Given this list of marker genes Cdk2, Rara, Cdk4, Cebpa, Rxra, Cdkn1a, here is a description of the gene set: species: Mus musculus Mouse Gene Set: REACTOME_TRANSCRIPTIONAL_REGULATION_OF_GRANULOPOIESIS Transcriptional regulation of granulopoiesis